Given this list of marker genes RNF20, SSR1, KIF5B, RNF144A, SP100, SPTY2D1, NR2F1, USP11, C11orf58, EPB41L4B, OSBPL8, PIK3AP1, CCER1, HLF, NAP1L1, LARP6, STRN3, SMIM10L1, ZNF41, SNX10, CTBP2, SOX2, ELAVL2, LIMA1, ZNF558 (zinc finger protein 558), ATP1B1, CNOT6, ZC3H6, CCPG1, PHTF2, VDAC1, COG6, CD44, EAF1, ZNF594, CXCL5, RGS7BP, ABLIM1, PI4K2B, CDKL5 (NCBI Gene Id 6792), NUP98, ESRP2, AKT3, TRMT11, MCOLN2, TBPL1, SLC5A3, CEP63, TMX3, DIAPH3 (NCBI Gene Id 81624, diaphanous related formin 3), KLHL2, BTBD8, PPTC7, SUPT7L, LPAR6, ANKRD27, ELP3, CCNT2, DDX3X, BBX, INSR, ZBTB7A, USP33, MS4A12, GABPA, FAM91A1, CTSC, MITF, DACH1 (dachshund family transcription factor 1), ETV6, NIPAL1, AK4, WDFY4, PDE6D, APOB (NCBI Gene Id 338), SH3RF3, SLITRK5, SINHCAF, IMPG2 (interphotoreceptor matrix proteoglycan 2), EPN2, PGAP1 (NCBI Gene Id 80055), IGF1, FRRS1L, ERO1A, PPP3CB, PRUNE2, LEPROT, EOGT, CCL17, SUCO, FIP1L1, ATXN1L, WDCP, PADI1, NUCKS1, NAPG, NCOR1, CDK14, SLC4A4, IPMK, RSBN1L, PPP3R1, MRAS, PSMA5, AGFG1, RSF1, ZDHHC15 (zinc finger DHHC-type palmitoyltransferase 15), KBTBD6, TENT4B, DDX4, KATNBL1, TFDP1 (transcription factor Dp-1), PAN3, RER1, MGST2 (microsomal glutathione S-transferase 2), GRM5, ZNF451, ZNFX1, DAAM1, PCDH9, MTUS1 (microtubule associated scaffold protein 1), RSRP1, ZSWIM7, RC3H1 (ring finger and CCCH-type domains 1), LRRC58, NR4A3, FBXO3, ING2, DPY19L4, XRCC2, AHR, ZBTB41, SLC39A3, FARP1, FEM1C, MIEF1, ZNF680, COL24A1, LIN28B, UBE2E2, MRPL17, ZNF704, NEXN, TFAP2A, GRK5, EEA1, ATOSA, HDAC9, DDX28, NHSL1, GHITM, NOTCH3, LYSMD2, CSTF2T, NR2F2, BPNT2, SPMIP4, SEC14L1, SPRY3, MAGI2, GCH1, TLCD3A, SLC24A2, CDH11, SLIT2, ALS2, DSTYK, TREM1, YWHAQ, HOOK3, GNAL, ONECUT2, PRKCI, YWHAG, PRRC1, HEY2, HYAL4, CARD8, PTCHD1, ZNF624, TRIM13, CSNK1G3, BAAT, MSL2, TRIM5, DCAF10 (DDB1 and CUL4 associated factor 10), PKP2, DIDO1, KIAA1549L (KIAA1549 like), TIA1, AAK1, FAM120A, here is a description of the gene set: Genes predicted to be targets of miRBase v22 microRNA hsa-miR-7161-5p in miRDB v6.0 with MirTarget v4 prediction scores > 80 (high confidence targets). from publication Chen Y, Wang X (PMID 31504780) Human Gene Set: MIR7161_5P species: Homo sapiens